The following is a description of a gene set: species: Homo sapiens Human Gene Set: GOBP_CORPUS_CALLOSUM_MORPHOGENESIS The process in which the anatomical structures of the corpus callosum are generated and organized. The corpus callosum is a thick bundle of nerve fibers comprising a commissural plate connecting the two cerebral hemispheres. It consists of contralateral axon projections that provides communications between the right and left cerebral hemispheres., and this is the list of marker genes: TSKU, PRDM8, C12orf57, ZEB2, SZT2, PAFAH1B1, NIN